Given this list of marker genes AQP5, KLK11, KRT16, KRT9, KLHL24, KRT1, RHBDF2, SNAP29, SERPINA12, SLURP1, JUP, here is a description of the gene set: species: Homo sapiens Diffuse palmoplantar hyperkeratosis Human Gene Set: HP_DIFFUSE_PALMOPLANTAR_HYPERKERATOSIS Diffuse abnormal thickening of the skin on the palms and soles.